The following is a description of a gene set: Genes that exhibit a postive CJAMP (Copula-based joint analysis of multiple phenotypes) beta estimate (beta > 0) for association with subcutaneous adipose tissue mass. from publication Konigorski S, Janke J, Patone G, Bergmann MM, Lippert C, Hübner N, Kaaks R, Boeing H, Pischon T (PMID 35953519) studied in species Homo sapiens Many studies have shown that abdominal adiposity is more strongly related to health risks than peripheral adiposity. However, the underlying pathways are still poorly understood. In this cross-sectional study using data from RNA-sequencing experiments and whole-body MRI scans of 200 participants in the EPIC-Potsdam cohort, our aim was to identify novel genes whose gene expression in subcutaneous adipose tissue has an effect on body fat mass (BFM) and body fat distribution (BFD). The analysis identified genes associated with adiposity, of which 531 encode a known protein and 487 are novel candidate genes for obesity. Enrichment analyses indicated that BFM-associated genes were characterized by their higher than expected involvement in cellular, regulatory and immune system processes, and BFD-associated genes by their involvement in cellular, metabolic, and regulatory processes. Mendelian Randomization analyses suggested that the gene expression of genes was causally related to BFM and BFD. Six genes were replicated in UK Biobank. Human Gene Set: KONIGORSKI_INCREASED_SUBCUTANEOUS_ADIPOSE_TISSUE_MASS_UP, and this is the list of marker genes: BRCA2, CDKN2A, RABGGTA, IL18, GALM, MAN2B1, SCAMP5, CES1, ABCC1, CLPTM1L, MOXD1, GINS4, WASHC3, NECAP2, ACTN1-DT (NCBI Gene Id 161159), EEIG2, CORO1C, MELK, RRM2B, FCGBP, BEND6, DCHS2, ASPM, HPD, SCN8A, HAVCR2, TMEM183AP2 (TMEM183A pseudogene 2), ABHD4, HTRA1, GLMP, ENSG00000274248, SLC41A2, HJURP, HMOX1, SNAP25, MVP (major vault protein), SLC22A12, FEZ1, CFAP107, MMP24, AADACL3 (NCBI Gene Id 649285), CST3, GPLD1, CPA4, P2RX7, TRAPPC1, TGM5, COL11A1, H1-2, ERAP1, PTPRU (NCBI Gene Id 10076), SEMA3C, LINC01426, CTSB, NRP2, GM2A, MFAP5, CYTOR, GRN, SDHAF2, NQO1, SLC4A3, CD248, PLBD2, ACTN1, YKT6, FTH1, CEP55, TLL1, CCN2, BCAT1, PCBP3, PFN1, TUBB2B, GCNT1, PKM, ZDHHC24, ANKRD30B, OSMR, AP1B1, XXYLT1 (xyloside xylosyltransferase 1), GRB2, IL4I1, DLEC1, RAB5IF, P2RX6P (purinergic receptor P2X 6 pseudogene), CCL21, SFRP4, THAP8, FCGRT, CDK14, GAPLINC, ARSB, CMTM3, KIF3B, ARMS2, TLE6, TPM3, TGM1, GPR39, MKI67, TMEM139, DAW1, C2, WWC1, DNASE2, POPDC3, LINC01503, HOMER3, LINC01013, STK17A, SH2D4A, EMILIN2 (NCBI Gene Id 84034), ALDH1A3, ANKDD1A, CLU, NMRAL2P, UCHL1, KIFC1 (kinesin family member C1), SLC25A20, ANXA5, GCNT2, ACP5, TUBB2A, RABAC1, ENO1, PLIN3, CDC20, SLC2A5, TSHZ2, FGD6, SLC35G1, FAM171A1, TFPT, CSTA, AKR1C1, AKR1C3, CYB561A3, SLC7A4, ANGPT2, FKBP1A, TNFAIP3, S100A4, ST3GAL4, LINC00184, CALD1, LRMDA, TMSB10, PDLIM2, FNDC10, GUK1, CASP12 (caspase 12 (gene/pseudogene)), CTHRC1, AFG1L, CLIP3, LINC02817, RAB7B, H2BC4, NPC2, PPP2R5C, MECR, EMC10 (ER membrane protein complex subunit 10), ITIH5, ARPC2, GASK1B, CCDC71L, FER1L6, PHETA1, QSOX1, ADAMTS3, IKBKE, H2AZ1, GNS, TRPM3, ZNF541, NCAPH, NUP188, HSD11B1, GLIPR2 (GLI pathogenesis related 2), TPTEP1, SYNGR2, CAPZB, CCPG1, C10orf90, ZNF516-DT, ALCAM, LINC01192, ARSJ, PEG10, SLC1A4, SLC36A2, CRYBB1, NSF, NALCN, AKR1C2, GMFB, MYL12A, CDK5, PPIAP46, MAN1B1-DT, DBNDD1, TOP2A (NCBI Gene Id 7153), SLC22A18AS, H4C8, HPS1, LINC02338, RNF182, LIMK1, TSPAN33 (NCBI Gene Id 340348), ANKRD1, NRAS, FGF1, COPE, CFL1, AKIRIN2, FAM118B, ID2, TNC, MSC-AS1, LINC00963, TPD52, TINF2, CDKL1, STX6, TNFRSF10D, SARDH, CADM3, AQP11, ZNHIT1, JAKMIP3 (Janus kinase and microtubule interacting protein 3), CFAP221, PALLD, TMEM208, RPN2, HTR7, GALE, ABCC3, VOPP1, SLC38A10, GAPDH, SPAG17, CYP11A1, LINC01914, SNCG, PI4K2A, AOC2, UNC13C, STMN2, BCYRN1, GNG2, FAT2, LBP, AKR1B1, AP2M1, SULT1A1, HMBS, RAB3C, TXNDC17, MFSD12, LINC01094, TNFRSF11B, COMMD7, YWHAB, FAR2, F2R, SERINC2, RAB29, ZFAT, PSAP, GALNT1, ATOX1, GBA1, EBI3, STMP1, AMPD3, CD84, SMIM43, LSM4, TNFRSF11A, EIPR1, E2F1, IRF8, NEK6, PLAAT4, KIAA0930, LINC02798, KIF9, PRKG2, P4HA3, TENM4, PRL, ZDHHC20, LAIR1, MAP4K4, LAMB3, SHANK1, TMEM160, ASAH1, ARHGAP28, SPARC, MSC, FTL, ADAM12, FAM151A, CCN5, SHTN1, MYOF, TRIM16L, RAP2A, SFRP2, TMC5, KIF3C, SNCAIP, LGALS8, IFITM10, GALNT10, SDSL, ZIK1 (zinc finger protein interacting with K protein 1), CNTNAP4, CCL19, TPST2, UBE2QL1, DTYMK, KCNQ3, INMT, C3AR1 (complement C3a receptor 1), MIEN1, S100A11, P2RX6, PDE1A, TMED3, GRIN2B, CYB561, PLAC9, LEP, MSANTD3, LINC02015, EHD4, GPX1, PLEKHO2, GLB1, CYP19A1, FAP, HES2, FAM225A, BBLN, BST1, AP2S1